The following is a description of a gene set: Any process that stops, prevents or reduces the frequency, rate or extent of signal transduction by p53 class mediator. Human Gene Set: GOBP_NEGATIVE_REGULATION_OF_SIGNAL_TRANSDUCTION_BY_P53_CLASS_MEDIATOR studied in species Homo sapiens, and this is the list of marker genes: MARCHF7 (NCBI Gene Id 64844), ATAD5, RNF34, MUC1, BCL2, BCL2L12, AARS1, RRM2B, NOP53, TAF1, KDM1A, BDKRB2, PRKN, RRN3, MDM2, YJU2, SNAI1, CD74, MIR21, CSNK2A1, ELL3, TRIAP1, MORN3, MIF, CD44, ARMC10, ING2, PTTG1IP, DYRK1A, RFFL, TAF3, TAF9B, MLXIPL, SIRT1 (NCBI Gene Id 23411), TWIST1, SNAI2, TAF9, PSMD10, DYRK3, HAPSTR1, ZNF385A